Given this list of marker genes Slc2a6, Esrrb, Gpd1, Eno3, Col6a1, Htr2a, Pkm, Fbp1, Mlx, Gapdhs, Fkrp, Slc4a1, Prkaa1, Pfkm, Eif6, Hif1a, Gapdhrt, Ucp2, Mlst8, Gale, Dhtkd1, Nupr1, Art2b, App, Foxk2, Pnp2, Jmjd8, Aldoart1, Mlxipl, Pgam1 (phosphoglycerate mutase 1), Tkfc, Mpi, Ddit4, Rptor, Trex1, Parp14 (poly (ADP-ribose) polymerase family, member 14), Ier3, Eno4, Qprt, Gapdhrt2, Zbtb20, Kat2b, Gck, Myog, Ppargc1a, Aox1, Sarm1, Pgk2, Stat3, Src, Prkaa2, Prkaca, Tigar, Psen1, Sik2, Pklr, Ep300, Ins2, Insr, Nudt12, Aldob, Ifng, Igf1, Ppp2ca, Hdac4, Prkag1, Pgk1, Foxk1, Nudt17, Pfkfb2, Sirt6, Pfkp, Git1, Aldoart2, Nudt13, Prxl2c, Pfkl, Ogt, Eno2, Hkdc1, Actn3, Ins1, Mfsd8, Arl2, Enpp1, Tpi1, Uchl1, Pdxp, Ncf2, Zbtb7a, Pfkfb1 (NCBI Gene Id 18639), Hk3, P2rx7, Galk1, Il3, Mtch2, Prkag2, Ncf1, Ppara, Bcl2l13, Hk2, Lipa, Bpgm, Gapdh, Cbfa2t3, Slc4a4, Hk1, Galt, Eno1, Flcn, Mtor, Ogdh, Pfkfb3, Nnmt, Khk, Pgam2, Gpi1, Ncor1, Adpgk, Arnt, Aldoa, Art2a, Aldoc, Myc, Prkag3, Trim63, Pnp, Eno1b, here is a description of the gene set: studied in species Mus musculus Mouse Gene Set: GOBP_PYRIDINE_CONTAINING_COMPOUND_CATABOLIC_PROCESS The chemical reactions and pathways resulting in the breakdown of a pyridine-containing compound, i.e. any compound that contains pyridine or a formal derivative thereof.